Given this list of marker genes IL22RA2, TLNRD1, ANXA3, CA2, MLKL, HOXB2, C18orf32, CD48, TRIM6, POGLUT1 (protein O-glucosyltransferase 1), NOPCHAP1, KIF2A, DYDC2, MELTF, ECD, DUSP1, POMP, HTR7P1, CCL2, C12orf75, CYP7A1, RMC1 (regulator of MON1-CCZ1), MAP3K14, TTLL4 (tubulin tyrosine ligase like 4), WARS1, UGGT2 (UDP-glucose glycoprotein glucosyltransferase 2), S1PR2, BCL2L13, GBP4, BTG1, CFAP184, BPI, CHMP4B, EOLA2, SLC36A4 (solute carrier family 36 member 4), ATP6V0E2, KDM2B, NME1 (NCBI Gene Id 7794), TMEM121B, IGFBP6, ITGA4, ZBED10P, CNNM4, NSMCE1, UPP1, ORC5, CLPB, CYP27B1 (NCBI Gene Id 5135), KCNE3, TMX2, IRAK1, MED8, SLC7A5, RAB20, FAM20C, CD1D, PSAP, USP11, CD40, C15orf48, SEL1L3, GFOD1, SLC20A2, GSDME (NCBI Gene Id 1687), DPY19L3, CCL17 (NCBI Gene Id 6361), CHST15, RPS6, SLC25A15 (solute carrier family 25 member 15), DOCK5, CYBB, ENO3, CFAP251, G0S2, CD274, PRDX6, CD72, CCR7, OXER1, FSCN1, RHBDF2, FAH, UCK2, VOPP1, GANC, NRIP1, CFP, NUB1, CDKN1A, ARFRP1, R3HDM2 (NCBI Gene Id 51220), PSMD4, EOLA1, PRXL2B, SNN (NCBI Gene Id 8303), PSME2, TGFA, LIMCH1, EIF1B, SIGLEC7, PIP5K1C, C2CD2L, ITPRIPL2, NFKBID, ABCB4, ST20, RGS12, SYNJ2, ACOX2, GATD3, TNFAIP2, HOXB6, UBE2D1, CHCHD4, F8, MYL5, EDDM3B, SAT1, TNNI2, CCT2, GUSB, RFLNB, RGS1, FLT3, PMAIP1, COL4A2 (collagen type IV alpha 2 chain), AMPD3, SFRP4, IFT88, OSGIN2, TBC1D13, AKTIP, SLC9A3-OT1, COQ10B, OR7E36P, ELOC, BTLA (NCBI Gene Id 151888), SPG21, GTF2E2, SSH1, MT1F, EEF2, BIRC3, CD83, LINC00294, PDGFB, LRRC32, GPX1, CD55, PPP1R14A, ALKBH3, MARCKSL1, LIAS, MCM2, TMEM268, RGCC, CD3D, CPEB1, SLC3A2, STX18, MB, GALM, HYOU1, CRIP1, CD84, KCTD7, BBS5, FAM107B, TRAPPC14, MMD, RUNX3, GPR157, SIGLEC17P, MOB3A, HIVEP2, IDO1, NUDT19, SINHCAF, PLGRKT, NEFH, MTMR14, BDH1, TESK1, CFAP68, ASB2, DOP1B, SNX27, ICOSLG, ANKRD33B, ACVRL1, MYADM, CD300LF, RYBP, SDHB, CCDC71L, SIPA1, WDR5, TBC1D1, LAMP3, here is a description of the gene set: T cell anergy is one of the mechanisms contributing to peripheral tolerance, particularly in the context of progressively growing tumors and in tolerogenic treatments promoting allograft acceptance. We recently reported that early growth response gene 2 (Egr2) is a critical transcription factor for the induction of anergy in vitro and in vivo, which was identified based on its ability to regulate the expression of inhibitory signaling molecules diacylglycerol kinase (DGK)-a and -z. We reasoned that other transcriptional targets of Egr2 might encode additional factors important for T cell anergy and immune regulation. Thus, we conducted two sets of genome-wide screens: gene expression profiling of wild type versus Egr2-deleted T cells treated under anergizing conditions, and a ChIP-Seq analysis to identify genes that bind Egr2 in anergic cells. Merging of these data sets revealed 49 targets that are directly regulated by Egr2. Among these are inhibitory signaling molecules previously reported to contribute to T cell anergy, but unexpectedly, also cell surface molecules and secreted factors, including lymphocyte-activation gene 3 (Lag3), Class-I-MHC-restricted T cell associated molecule (Crtam), Semaphorin 7A (Sema7A), and chemokine CCL1. These observations suggest that anergic T cells might not simply be functionally inert, and may have additional functional properties oriented towards other cellular components of the immune system. species: Homo sapiens from publication Zheng Y, Zha Y, Spaapen RM, Mathew R, Barr K, Bendelac A, Gajewski TF (PMID 23548837) Human Gene Set: GSE46242_TH1_VS_ANERGIC_TH1_CD4_TCELL_WITH_EGR2_DELETED_UP Genes up-regulated in CD4 Th1 cells with EGR2 knockout: control versus anergic.